Given this list of marker genes FLNA, VCL, CNN2 (calponin 2), GSN, CFL1, SPTBN1, CXCR4, TPM4, SVIL, FLNB, MYH11, STMN2, MYH9, ENC1 (ectodermal-neural cortex 1), PLS3, PIP, CAPZA2, CALD1, DSTN, IGF2, ACTN4, CNN3 (NCBI Gene Id 1266), MARCKS, SPTAN1, WDR1, SYN1, FLII, LMOD1, MACF1, FLNC, here is a description of the gene set: Actin cytoskeleton binding. Human Gene Set: MODULE_524 studied in species Homo sapiens